The following is a description of a gene set: Reactome Pathway: Drug ADME species: Homo sapiens Pharmacokinetics (PK) is a branch of pharmacology dedicated to determining the chemical fate of substances in living organisms, from administration to elimination from the body. PK can be described as how an organism affects a drug, whereas pharmacodynamics (PD) is the study of how a drug affects the organism. Both PK and PD are described for each drug annotated in the Drug Absorption, Distribution, Metabolism and Excretion (ADME) pathways. For example, although paracetamol ADME (PK) is described in this section, the pharmacological inhibition (PD) of its targets (PTGS1 and PTGS2) is described in the relevant pathway where these enzymes perform their physiological duties. A connection is made between the two pathways to link PK and PD annotations.<br><br>The disposition of a pharmaceutical compound within an organism can be described by four main stages; absorption, distribution, metabolism, and excretion, abbreviated to ADME. Sometimes, separate steps can be tacked on to ADME depending on what is being described. For example, where a drug is released from a pharmaceutical formulation, liberation (L) is added to ADME (LADME) or where the toxicity of a compound is described, T is added (ADMET).<br><br>ADME of various drugs is annotated in this section., and this is the list of marker genes: GMPS, RAC1, GUK1, GLYATL3, ACSM4, UGT2B4, GSTM1, UGT2A1, UGT2B15, UGT1A5 (UDP glucuronosyltransferase family 1 member A5), SLC22A7 (solute carrier family 22 member 7), SULT1A4, UGT1A7 (NCBI Gene Id 54577), ABCC2, SLC22A1, ADK, ABCC1, CNDP2, SLCO1A2, UGT2B11, NME2, SLCO2B1, GSTA2, SULT1E1, HSD11B2, UGT1A9, SLC29A1, SLC29A2, SERPINA6, GLYATL2, TPMT, GSTT1, NAT1, ADA, ALB, UGT2A3, GSTP1, NAT2, NME1, GGT5, ABCC5, CYP2D6, CYP3A4, UGT1A6, UGT1A4, SLCO1B1, ABCC4, SLC29A3, UGT3A1, CES1, ACSM5, SLC28A2, XDH, VAV2, UGT2A2, PON3, IMPDH1, MAPDA, SULT1C4, SLC16A1, ABCC3, VAV1, SLC22A2, SLC22A3, UGT2B7, ACSM2A, IMPDH2, SLC28A3, HPRT1, ADH1A, ABCB1, BCHE, GSTA1, ACY1, CYP2E1, UGT1A8, SULT1A3, ABCG2, UGT1A1, GGT3P, PCK1, SLC22A8, ITPA, UGT2B10, GLYAT, CYP2C19, AKR1C1, NT5C2, GLYATL1, SULT2A1, UGT1A3, HSD11B1, PNP, GGT1, UGT2B28, CYP2C9, ACSM2B, NUDT15, UGT2B17, GGT7, SLCO1B3, BSG, VAV3, GGT6, UGT1A10, CES2 (carboxylesterase 2), PON1, SULT1A1 (sulfotransferase family 1A member 1), UGT3A2, CYP2C8